Given this list of marker genes Ndufaf4, mt-Nd3, Coq10a, Ndufa7, Ndufa13, Uqcr10, Cox4i1, Iscu, Ndufb8, Got2, Slc25a11 (NCBI Gene Id 67863), Ndufaf5, Cycs, Ndufc1, Slc25a13, Ndufa10, Ndufv3, Cox7c, Nubpl, Cox6a1, Lyrm4, Ndufs8, Ndufa12 (NCBI Gene Id 66414), Hccs (NCBI Gene Id 15159), Cox7a1, Uqcrfs1, Cox17, Uqcrc2, Slc25a22, Ndufaf7, Cox6a2, Mdh2, Pyurf, Cox7a2l, Uqcr11, Higd2a, Slc25a18, Cox20, Sco2, Cox18, Ndufb1, Cox14, Ndufv2, Ndufs3, Fxn, Ndufaf3 (NCBI Gene Id 66706), mt-Cytb, Cox6c, Higd1c, Tmem126b, Ndufb10, Ndufb9, Cyc1, Ndufs7, mt-Nd6, Cox11, Ndufa5, Got1, Coa5, Cox5a, Ndufa2, Ndufa4, Ecsit, Ndufaf1, Cox8a, Ndufaf6, Ndufs5 (NADH:ubiquinone oxidoreductase core subunit S5), Ndufb3, Ndufs6, Cox8c, Ndufa9, Cox4i2, Tmem177, here is a description of the gene set: studied in species Mus musculus Reactome Pathway: Respiratory electron transport electronically inferred by orthology from the curated human pathway part of: Aerobic respiration and respiratory electron transport This event has been computationally inferred from an event that has been demonstrated in another species.<p>The inference is based on the homology mapping from PANTHER. Briefly, reactions for which all involved PhysicalEntities (in input, output and catalyst) have a mapped orthologue/paralogue (for complexes at least 75% of components must have a mapping) are inferred to the other species.